Given this list of marker genes PDE4C, HDC, ENTPD1, CAMK1, KRT86, GDPD5, ALOX5, IL10RA (interleukin 10 receptor subunit alpha), CPA3, HBA1, FCER1A, NCF1, PILRA, PMP22, ALOX5AP, CYP1B1, MS4A2, ADAM8 (NCBI Gene Id 101), here is a description of the gene set: Genes down-regulated in granulocytes by RUNX1-RUNX1T1 fusion. studied in species Homo sapiens Human Gene Set: TONKS_TARGETS_OF_RUNX1_RUNX1T1_FUSION_GRANULOCYTE_DN from publication Tonks A, Pearn L, Musson M, Gilkes A, Mills KI, Burnett AK, Darley RL (PMID 17898786) The t(8;21)(q22;q22) occurs frequently in acute myelogenous leukaemia and gives rise to the transcription factor fusion protein, RUNX1-RUNX1T1 (also known as AML1-ETO). To identify the genes dysregulated by the aberrant transcriptional activity of RUNX1-RUNX1T1, we used microarrays to determine the effect of this mutation on gene expression in human progenitor cells and during subsequent development. Gene signatures of these developmental subsets were very dissimilar indicating that effects of RUNX1-RUNX1T1 are highly context dependent. We focused on gene changes associated with the granulocytic lineage and identified a clinically relevant subset of these by comparison with 235 leukaemia patient transcriptional signatures. We confirmed the overexpression of a number of significant genes (Sox4, IL-17BR, CD200 and gamma-catenin). Further, we show that overexpression of CD200 and gamma-catenin is also associated with the inv(16) abnormality which like RUNX1-RUNX1T1 disrupts core binding factor activity. We investigated the functional significance of CD200 and gamma-catenin overexpression in normal human progenitor cells. The effect of IL17 on growth was also assessed. Individually, none of these changes were sufficient to recapitulate the effects of RUNX1-RUNX1T1 on normal development. These data provide the most comprehensive and pertinent assessment of the effect of RUNX1-RUNX1T1 on gene expression and demonstrate the highly context-dependent effects of this fusion gene.